Given this list of marker genes NMNAT1, ADAR, IFT74, OCA2, MC1R, here is a description of the gene set: Human Gene Set: HP_MACULAR_HYPOPIGMENTATION species: Homo sapiens Decreased amount of pigmentation in the macula lutea. Macular hypopigmentation